Given this list of marker genes CREB3, ADCY8 (NCBI Gene Id 114), CREB1, ADCY4, CREB3L4, PRKACA, PRKACB, ADCY7, ADCY5, ATF2, ATF6B, GNAI2 (NCBI Gene Id 2771), ADCY2, PRKACG, CREB3L1, CREB3L3, GNAI1, ATF4, GNAI3, RASD1, ADCY3, POMC, ADCY6, CREB3L2, CREB5, ADCY9, ADCY1, here is a description of the gene set: studied in species Homo sapiens Human Gene Set: KEGG_MEDICUS_VARIANT_MUTATION_INACTIVATED_RASD1_TO_CRHR_PKA_ACTH_SIGNALING_PATHWAY Pathway Definition from KEGG: RASD1* // GNAI // ADCY -> cAMP -> PKA -> CREB -> ACTH Mutation-inactivated RASD1 to CRHR-PKA-ACTH signaling pathway. Pathway ID: N00325. Pathway type: Variant. Pathway class: nt06310 CRH-ACTH-cortisol signaling.